The following is a description of a gene set: Growth hormone receptor signaling Human Gene Set: REACTOME_GROWTH_HORMONE_RECEPTOR_SIGNALING studied in species Homo sapiens, and this is the list of marker genes: MAPK1, STAT1, SH2B1, SOCS1, PTPN1, GH2 (growth hormone 2), IRS2, JAK2, PRL, CSH1, GH1, PRLR, LYN, GHR, PTPN6, CISH, MAPK3, SOCS3, SOCS2, STAT5B (NCBI Gene Id 6777), ADAM17, STAT5A, STAT3, IRS1